Given this list of marker genes CEP57, ERBB2, POLD1, COL14A1 (NCBI Gene Id 7373), IRF1, CDH1, SEMA4A, KRAS, ATM, BRCA2, IL1RN, BMPR1A, TP53, CHEK2, TRIP13, KLF6, MUTYH, BUB1B, FGFR2, APC, PIK3CA, CASP10, IL1B, CDKN2A, POLE, MSH3, BUB3, BLM, BUB1, AAGAB, RPS20, MDM2, STK11, here is a description of the gene set: A cancer arising in any part of the stomach. studied in species Homo sapiens Human Gene Set: HP_STOMACH_CANCER Stomach cancer